Given this list of marker genes CCL2 (C-C motif chemokine ligand 2), POLR3G, AREG, PAX8, LRP12, SAT1, SOD2, ANGPTL4, SMURF2, MAPKAPK5, here is a description of the gene set: studied in species Homo sapiens The cytokine scatter factor (SF) (hepatocyte growth factor) transduces various biologic actions, including cell motility, invasion, angiogenesis and apoptosis inhibition. The latter is relevant to understanding the role of SF in promoting tumor cell survival in different contexts, for example, detachment from basement membrane, growth in metastatic sites and responses to chemo- and radiotherapy. Previously, we showed that SF protects cells against apoptosis owing to DNA damage, by a mechanism involving phosphoinositol-3-kinase/c-Akt signaling. Here, we used DNA microarray assays to identify c-Akt-regulated genes that might contribute to cell protection. DU-145 human prostate cancer cells were transfected+/-a dominant-negative mutant Akt, treated+/-SF and analysed for gene expression using Affymetrix arrays. These studies identified SF-regulated genes for which induction was c-Akt-dependent vs -independent. Selected microarray findings were confirmed by semiquantitative and quantitative reverse transcription-polymerase chain reaction. We tested the contribution of four SF-inducible/c-Akt-dependent genes (AMPD3, EPHB2, MX1 and WNT4) to protection against adriamycin (a DNA topoisomerase IIalpha inhibitor) using RNA interference. Knockdown of each gene except EPHB2 caused a small but significant reduction in the SF cell protection. The lack of effect of EPHB2 knockdown may be due to the fact that DU-145 cells contain a single-mutant EPHB2 allele. A combination of three small interfering RNAs blocked most of the protection by SF in both DU-145 and T47D cells. These findings identify novel c-Akt-regulated genes, some of which contribute to SF-mediated cytoprotection. Human Gene Set: XU_HGF_TARGETS_REPRESSED_BY_AKT1_UP from publication Xu J, Gao M, Fan S, Meng Q, Goldberg ID, Abounader R, Ressom H, Laterra JJ, Rosen EM (PMID 17099727) Genes up-regulated in DU-145 cells (prostate cancer) in the presence but not in the absence of a dominant negative form of AKT1 upon exposure to HGF for 48 h.